Given this list of marker genes APP, COBL, WNT3, SPART, WNT3A, here is a description of the gene set: studied in species Homo sapiens The process in which outgrowths develop from the axons of intact undamaged neurons. Human Gene Set: GOBP_COLLATERAL_SPROUTING_IN_ABSENCE_OF_INJURY